Given this list of marker genes H4C12, H2BC5, RNU5E-1, H2BC7, H4C11, H2AC11, WDR74, H3C10, here is a description of the gene set: studied in species Homo sapiens Genes containing one or more binding sites for (COIL) in their promoter regions (TSS -1000,+100 bp) as identified by GTRD version 20.06 ChIP-seq harmonization. Human Gene Set: COIL_TARGET_GENES from publication Yevshin I, Sharipov R, Kolmykov S, Kondrakhin Y, Kolpakov F (PMID 30445619)